Given this list of marker genes Srsf2, Cpsf6, Smarca4, Nufip1, Trim24, Tardbp, Clock, Dhx9, here is a description of the gene set: studied in species Mus musculus Structures of variable diameter visible in the nucleoplasm by electron microscopy, mainly observed near the border of condensed chromatin. The fibrils are enriched in RNA, and are believed to be sites of pre-mRNA splicing and polyadenylylation representing the in situ form of nascent transcripts. Mouse Gene Set: GOCC_PERICHROMATIN_FIBRILS